The following is a description of a gene set: Genes having at least one occurrence of the highly conserved motif M91 GTGGGTGK in the regions spanning 4 kb centered on their transcription starting sites. The motif does not match any known transcription factor binding site. species: Homo sapiens Human Gene Set: GTGGGTGK_UNKNOWN from publication Xie X, Lu J, Kulbokas EJ, Golub TR, Mootha V, Lindblad-Toh K, Lander ES, Kellis M (PMID 15735639) Comprehensive identification of all functional elements encoded in the human genome is a fundamental need in biomedical research. Here, we present a comparative analysis of the human, mouse, rat and dog genomes to create a systematic catalogue of common regulatory motifs in promoters and 3' untranslated regions (3' UTRs). The promoter analysis yields 174 candidate motifs, including most previously known transcription-factor binding sites and 105 new motifs. The 3'-UTR analysis yields 106 motifs likely to be involved in post-transcriptional regulation. Nearly one-half are associated with microRNAs (miRNAs), leading to the discovery of many new miRNA genes and their likely target genes. Our results suggest that previous estimates of the number of human miRNA genes were low, and that miRNAs regulate at least 20% of human genes. The overall results provide a systematic view of gene regulation in the human, which will be refined as additional mammalian genomes become available., and this is the list of marker genes: TRIM55, PKP1, SOX15, PRMT3, MYO10, TGFBR1, LRP1, RBMS3 (RNA binding motif single stranded interacting protein 3), ARFGEF1, PIP4K2B, DCUN1D3, ZCWPW1, DYNLL1, MAPK10, FSTL1, GRIA1, SOWAHA, IGF1 (NCBI Gene Id 3479), BASP1, CHKA, LPAR1, SSTR3, SLIT3, KCNH2, CTNNA3, ZSCAN20, PTHLH, NOTCH2NLA, TXLNG, HOXD13, SHH, ATP2B4, BCL11A, PAK3, AHCYL1, AMMECR1L, CFAP53, TMEM184B, MAPT, PRKCH, BLMH, DLGAP4, RNF111 (ring finger protein 111), PCBP4, MMP28, UCHL1, SMYD2, DMXL1, PRX, ZNF800, ELAVL2 (NCBI Gene Id 1993), FAM110D, ARPC2, ATP2B3, MEPCE, CA14, CAPRIN1, EXOC6, BCOR, KCNK9, CLTC, GIT1, SOCS1, PIGV, ASIC2, PPP1R1B, SORBS1, TWIST1, ITPRIPL1, OAZ2, THPO, GRM3, KPNB1, CHRM1, EHF, OTUB2, NEUROD2, CUEDC1 (NCBI Gene Id 404093), KRTAP6-1, SMARCA1, KLF7, LIN54, CRACDL, GPR132, HOXB4, IGF2BP1, PER2, CACNA1A, HTR1B, C22orf31 (chromosome 22 open reading frame 31), ZMYND8, HAS2, OSM, FAM89B, NECTIN1, PNOC, SCAMP5, LZTS2, CHRDL1, LRCH2, PGF, SPTB, MARCKSL1, KLF12, DMP1, PI15, NOTCH2, GABRA1, FES, DTNA, MBOAT2, PRRX1, FGF10, TUB, PRUNE2, JADE2, TUBB2B, PTPRG, RNFT1, SEMA3B (semaphorin 3B), ZCCHC12, PHOSPHO1, DOC2A, SP2, PITX2, NCK2, PDGFB, CYTH3, APOBR, KCNH8, LINC00299, RUNX2, GABARAP, BHLHE40, TSHZ2, CDH22, STX12, MITF, PPP3CA, GNAI2, AGO1 (NCBI Gene Id 26523), DCN, SCAMP3, MID2, NADK, PTPN7, GPR3, CLCN2 (chloride voltage-gated channel 2), PURA, BAG1, MATN1, AARSD1, KCNH7, CTTNBP2NL, CDKN1B, CHRD, WNT2, SLC12A2, XCL1, TSPAN33, TRAF3IP1, LUZP1, RASA1, FASLG, TNFSF18, KCNQ5, SP4 (Sp4 transcription factor), HAS1, MAGED1, TPM1, CTNND1, PAFAH1B1, HBEGF, BCS1L, ZNF384, DEPDC4, BAHD1, NRGN, ANKRD13B, KRT33B, SLC25A12, MYCN, ABCD1, EPHA1, INKA2, LUC7L2, IGFBP6, LINC01312, SPARC (NCBI Gene Id 6678), ARHGAP6, TRPV3, CGGBP1, BCAP31, APP, MYCL, EEF1A1, ZFP36L1, HES7, KCNB2, NRIP3, PHYHIP, ZFPM1, ATP1B4, FOXD3, VEGFA, PCSK2, WNT10A (Wnt family member 10A), PRKCE, RAB25, FUT2, CPNE6, CCL22, PER1 (NCBI Gene Id 5187), RCOR2, HOXA3, CELF4 (CUGBP Elav-like family member 4), UBA6, EGR1, WNT7B, GSDMA, PVALEF, BARHL1, UBASH3B, ITGA2, COL27A1, RUNDC1, CASKIN2, CALM3, CTSW (NCBI Gene Id 8849), MTSS1, ACVR1C, GATA1, MINK1, PPP1R16B, NR3C1, EPB41L3, ATL1, PANK1, TMEM263, KRT17, MFSD5, DQX1, ADD3, EGR3, PIGP, TAOK1, ADISSP, MAP4K3, SHANK2, PCDH10, SCYL3, FAM110A, PPP2R2B, SERPINE1, LIX1, MTUS1, SLC36A2, ATOSB, KREMEN1, RRAGA, KCND1, CLPTM1, SEMA4C, KCND2, AGR2, ZHX2, FOXO3, CAPN6, ELMO3, DRD3, VTCN1, KRIT1, GSX1, CYLD, A2M, CFAP161, LCE1F, ASIC4, ACSL4, NR4A3, SOX10, THRA, CHMP5, TMEM54, NXPH3, FAM91A1, ATP5MC1, KMT2A, UTP18 (NCBI Gene Id 51096), SIRT1, LYRM1, ITPR1, RTL3, TFAP4, MAB21L3, POP5, PPARG, HOXB1